The following is a description of a gene set: Genes up-regulated in B cell 3d vs 0d in adults after exposure to 2011-2012 trivalent inactivated vaccine (A/California/7/09 (H1N1), A/Perth /16/2009 (H3N2), B/Brisbane/60/2008), time point 3D. Comment: Up-regulated DE RNA transcripts (up >= 1.5x) shared between both TIV-vaccinated donors studied in species Homo sapiens from publication Hoek KL, Samir P, Howard LM, Niu X, Prasad N, Galassie A, Liu Q, Allos TM, Floyd KA, Guo Y, Shyr Y, Levy SE, Joyce S, Edwards KM, Link AJ (PMID 25706537) Human Gene Set: HOEK_B_CELL_2011_2012_TIV_ADULT_3DY_UP Systems biology is an approach to comprehensively study complex interactions within a biological system. Most published systems vaccinology studies have utilized whole blood or peripheral blood mononuclear cells (PBMC) to monitor the immune response after vaccination. Because human blood is comprised of multiple hematopoietic cell types, the potential for masking responses of under-represented cell populations is increased when analyzing whole blood or PBMC. To investigate the contribution of individual cell types to the immune response after vaccination, we established a rapid and efficient method to purify human T and B cells, natural killer (NK) cells, myeloid dendritic cells (mDC), monocytes, and neutrophils from fresh venous blood. Purified cells were fractionated and processed in a single day. RNA-Seq and quantitative shotgun proteomics were performed to determine expression profiles for each cell type prior to and after inactivated seasonal influenza vaccination. Our results show that transcriptomic and proteomic profiles generated from purified immune cells differ significantly from PBMC. Differential expression analysis for each immune cell type also shows unique transcriptomic and proteomic expression profiles as well as changing biological networks at early time points after vaccination. This cell type-specific information provides a more comprehensive approach to monitor vaccine responses., and this is the list of marker genes: MIR3652, NRGN, BIK, CCNA2, HBB, PYCR1, CENPM, CDC20, SDC1, IGKV1-17, FNDC3B, SPN, NT5DC2, S100A9, PLAAT2, LINC00899, MAN1A1, AQP3, NCAPH, CHPF, PSAT1, MKI67, TYMS, CHEK1, TNFRSF17, SLAMF7, TRIB1, NBPF11, RRM2, HASPIN, CAV1, HBA2, FCN1, IGKV2D-30, SULT1A4, PLEKHG7, LGALS3, IGKV3D-20, MIXL1